Given this list of marker genes SCN9A, WNK1, RETREG1, CCT5, KIF1A, NTRK1, MPV17, SPTLC1, NGF, here is a description of the gene set: Human Gene Set: HP_ACRAL_ULCERATION A type of digital ulcer that manifests as an open sore on the surface of the skin at the tip of a finger or toe. species: Homo sapiens Acral ulceration